Given this list of marker genes ARID5A, NEURL3, MMS19, ANKRD39, MAPK3, DUSP2, MIR3127, KANSL3, COX11, ITPRIPL1, CNNM3, PARL, IL6, COL2A1, TMEM127, FAM178B, STARD7 (NCBI Gene Id 56910), MAPK1, PLXNB2, CIAO1, ASTL, STAT3, SEMA4C, SNRNP200, CIAO2B, FER1L5, LMAN2L, ZP2, RHOA, ANKRD23, ERBB2, ADRA2B, CIAO2A, CNNM4, NCAPH, here is a description of the gene set: 2q11.2 copy number variation syndrome species: Homo sapiens Human Gene Set: WP_2Q112_COPY_NUMBER_VARIATION_SYNDROME